The following is a description of a gene set: Reactome Pathway: Maturation of protein E_9683683 studied in species Homo sapiens The envelope protein (E) gets palmitoylated and ubiquitinated after translation. It forms trimers that show porin activity but does not localize to the cell membrane. part of: Translation of Structural Proteins, and this is the list of marker genes: E, UBC, UBA52, RPS27A, UBB